The following is a description of a gene set: Human Gene Set: HP_PECTORAL_MUSCLE_HYPOPLASIA_APLASIA studied in species Homo sapiens Pectoral muscle hypoplasia/aplasia, and this is the list of marker genes: MYMK, SALL4, ALX1, ALX3 (ALX homeobox 3), REV3L, ITPR1, TBX3, TBX5, MYMX, PLXND1